Given this list of marker genes BCL2L11, LMNA, CDK5, CAST, JUN, FASLG, LMNB1, CAPNS1, CDC25C, CDC25A, YWHAE, CAPN1, CDC25B, CDK5R1, PRDX1, CDKN2A, C1QBP, PRDX2 (NCBI Gene Id 7001), SOD2, GOLGA2 (golgin A2), CAPN2, APP, TP53, FOXO3, CAPNS2, here is a description of the gene set: species: Homo sapiens part of: Diseases of programmed cell death Defects in the regulation of the intrinsic pathway for apoptosis are involved in diseases associated with increased cell loss, such as neurodegenerative diseases, as well as in diseases associated with impaired elimination of harmful cells, such as cancer and autoimmunity. For review, please refer to Reed 2001, Lavrik et al. 2009, and Tuzlak et al. Reactome Pathway: Defective Intrinsic Pathway for Apoptosis